The following is a description of a gene set: species: Homo sapiens Any process by which the numbers of cells of a particular type or in a tissue are maintained. Human Gene Set: GOBP_MAINTENANCE_OF_CELL_NUMBER, and this is the list of marker genes: PTN (pleiotrophin), SUDS3, EZH2, KIT, NKAP, NR5A2, TEAD4, TET1, SOX9, KLF10, ZHX2, RAF1, JAG1, SETD6, LIF, NOTCH1, KAT2A, MED24, LSM1, SAP30, ACTB, NCOA3, IGF1, SIRT6, CUL4A, OGT, BRAF, LDB1, KDM4C, TBX1, YAP1, SMC1A, SOX2, ARID4B, EIF4E, SMARCD1, SMARCA2, FOXO1, ZIC1, PROX1, NANOG, TAF5L, MED27, EIF4ENIF1, RBBP4, REST, CNOT3, FUT10, SALL4 (spalt like transcription factor 4), ZIC3, NANOS2, TFAP2C, HDAC1, SPI1, NODAL, SOX4, TRIM8, HNF1B, FOXO3, MED14, NOG, TP63, MED12, MED21, FZD7, VANGL2, PRRX1, LINC-ROR, IGF2BP1, MED6, CTR9, ING1, SRRT, PADI4, ARID1A, LOXL2, ZNF358, SFRP1, BRMS1, PELO, BCL7C, HES1, SS18, LBH, ZNF322, SMARCB1, LIG4, TPT1, POU5F1, ING2, NANOGP1, STAT3, TBX3, CNOT2, ZC3H13, PAF1, CDC73, SMC3, RBPJ, MYC, WDR47, SAP130, SELENON, ELAVL1, BRD9, ACTL6B, HDAC2, MCPH1, WDR43, FGF10, TAF6L, KLF4, DIS3L2 (NCBI Gene Id 282696), DPF2, LEO1, SMARCE1, DSG2, MIR145, RBBP7, KDM3A, MED15, PAX8, CDX2, MED10, TAL1, HOOK3, MED17, SMC5, BMPR1A, MED28, SIN3A, DDX6, ACTL6A, ZFP36L2, MED30, SMARCA4, LRP5, TUT4, PRDM14, SAP30L, MTF2, BMP7, FANCD2, BSX, ARID4A, HES5, NANOGP8, ELF5, NR2E1, SMARCC1, LDB2, METTL3, ASPM, MMP24, YME1L1, LIN28A, BICRA, KDM2B, BICRAL (NCBI Gene Id 23506), HMGA2 (NCBI Gene Id 8091), PHF19, ESRRB, WNT7A, CTNNB1 (NCBI Gene Id 1499), NFIB, SMO, PIWIL2, LNCPRESS1, EOMES, TCF15, PAX2, BCL9, WNT9B, LRRC46, CNOT1, METTL14, PCM1, GATA2 (NCBI Gene Id 84724), CDKN2A, BCL7A, FGF4, BCL9L, SAV1 (NCBI Gene Id 60485), DLL1, RTF1, ZNF706, HESX1, PHF10, SKI, MED7, BRMS1L, ASCL2, RIF1, VPS72, CDH2, NIPBL, SIX2, GNL3, BCL7B (NCBI Gene Id 9275), SINHCAF